Given this list of marker genes MSRB3, MSRB2, FN3K, PARK7, MSRB1, PCMT1 (NCBI Gene Id 5110), MSRA, here is a description of the gene set: studied in species Homo sapiens Human Gene Set: GOBP_PROTEIN_REPAIR The process of restoring a protein to its original state after damage by such things as oxidation or spontaneous decomposition of residues.